Given this list of marker genes ING4, TFDP2, IRX4, KDM1A, PTGES2, DLX1, SBNO2, MIR137, EIF4A1, AHI1, MAP2K7, TCF20, NOTCH3, HAND2, E2F2, ZNF563, MIR24-1, CREB3, SREBF2, UHRF1, SMARCA2, UBE2E1, NCL, PPARA, ZBTB48, MED13, EBF4, BMAL1, DLX5, KLF4, MAPK3, ZNF780B, PTMS, NCOA6, INHBA (inhibin subunit beta A), ZNF292, MT3, HIVEP3, PID1, PAXBP1, NANOS1, TRIM24, TRA2B, EP300, ILF2, MIR365A, SIX3, POU2F1, OSR1, KLF7, CCNB1, BRD7, RBMY1A1, MEIS3P1, RXRB, PQBP1 (polyglutamine binding protein 1), SIX2 (NCBI Gene Id 10736), GABPA, SALL1, STAT4, ARGLU1, WWP2, RC3H1, TGFB2, CNOT3, CKAP2 (cytoskeleton associated protein 2), ZNF496, ONECUT1, TFR2, S1PR1, KDM7A, UBTFL6, UBP1, PRKD2 (protein kinase D2), GTPBP1, UPF1, PELP1, NR1D1, MSX1, ATM, MECOM, TOX, TBP, WWOX, ESRRG, RTRAF, GATAD2A, NR5A1, MIR18A, DLL1, CNOT2, IKBKB, TRIM52, DNM3OS, MIR26B, PLPP3, ESRRB, TLR9, TAF6L (NCBI Gene Id 55310), ICE2, ZNF550, ZFP36, NEUROD1, RBBP7, TNKS1BP1, CCAR1, ST18, IKBKG, SMAD5, CLOCK, EXOSC9, NHLH2, SHH, ARRB1, AGRN, ACTR5, TBX20, ZBED1, WDR43, LIF, FZD7 (frizzled class receptor 7), ZNF212, CAND2 (NCBI Gene Id 23066), ARID4B, FOXA3, MIR424, NEUROG3, MGA, TEAD1, PHOX2B, TNRC6A, MACC1, IL1A, PSEN1, PDLIM1 (NCBI Gene Id 9124), MEF2A, DAB2IP, MBTPS2, MITF, BSX, GIGYF2, TFAP2A, DCPS, HOXA4, EGLN1, CAMTA2, ZNF287, MIR519D, HMBOX1, RBMY1J, RBPMS (NCBI Gene Id 11030), PNLDC1, TADA1, RGCC, RREB1, TNF, ATF7 (activating transcription factor 7), TBX1, TMPRSS6, CDK5RAP2, TCF12, EGR1, BLM, PAX3, CD86 (CD86 molecule), TRIM31, CCNT2, MIR302C, BCL11A, CCNK, ZBTB18, PAX6, MIR93, LIN28B (NCBI Gene Id 389421), PIK3R1, PF4 (platelet factor 4), ATF2, YEATS4, CCN1, ZNF24, CRTC3, MET, PLAG1, GLI3, IL4I1, PSIP1, TRIM21, SPX, AR, HDGF, IER2, DIS3L2, MEIS3, ELF1, BCL2L12, WNT3A, MRTFA, APEX1, NFKB1, RIPK1, MSGN1, CHCHD2, SRF, DND1, IRF3, TAF1L, NKX2-6, TP63, HIPK2, ECD, PKN1, EGR3 (NCBI Gene Id 1960), MYRF, WASL, CPEB3 (NCBI Gene Id 22849), SMAD2, YTHDF3, ARNT2, MAVS, PRKD1, TCERG1, FOXF2, BUD23, ZNF516, IL6, PPRC1, HOXB9, SFRP2, THRAP3, OSM, ZNF407, DCN, BEX1, MIR708, EN1, MED29, TOPORS, XIST, TGFB3, HELZ2, CDC5L, FOXP3, NFE4, SMAD4, RBM15, NR4A2, ZNF711, YY1, MIR423, CHD4, MIR485, BPTF, NR4A3, FOSL2, DUX4, GATA5, NUP98, PITHD1, IRF1, MSL2 (NCBI Gene Id 55167), CCDC62, SPIB, PAXIP1, RBBP4, SMAD9, DRD2, NFE2L1, HOXC13, CLNS1A, CAMKK2 (NCBI Gene Id 121657), EPC1, BCLAF1, FIGLA, NCOA4, MIR483, MIR130A, PPP1CA, PER2, SMARCD2, NCK2, FGFR2, IL17F, GABPB1, THAP11, F2R, JUNB, XBP1, GRHL3, ZFP36L2, RGMB, FSTL3, GREM1, HAND1, FOXM1, PLAGL2, GATA6, NOL11, TADA2B, SF3B1, BTRC, CD81, SS18, FLI1, CREB3L2, BMPR1A, ELF2, NR1H4, PSMC6, SAMD4A, SOX3, CNOT8, RFXAP, MAML2, TMF1, SLC39A5, FGF1, HIVEP1, JMY, CDON, NFATC2, DEK, NANOG, NAA15, FXR2, MIR128-1, SKAP1, SOX9, LHX3, ZNF750, TAF5, BMPR1B, PCBD2, EIF2AK3, ATRX, PLSCR1 (NCBI Gene Id 5359), APBB2, TOX2, TNNI2, HAS3, IFNL1, ZNF76, DHX9 (NCBI Gene Id 3450), HOXA2, UCHL5, CSRNP3, NR5A2, CHURC1, LRP5, NOTCH4, RRN3, MEF2B, MIR125B1, ZBTB7C, ZNF593, HOXB4, EEF1D, PSMC3, MIR543, TAF2, NR2F1, MBTD1, MYOCD (myocardin), ZNF268, TFPT, DLX2, ETV6, ZXDA, MIR181B1, NFIC, SUPT4H1 (SPT4 homolog, DSIF elongation factor subunit), HSPA5, SERTAD1, MYCBP, SATB2, KLF10, CHD6, MIR27A, RBM23, ATMIN, MED18, ZEB2, NAT14, MALAT1, ZNF597, HCFC1, ZNF410, E4F1, MRTFB, RBMY1D, WNT8A, TET1, ZIC2, ATOH7, APBB1, NR1I3, ZNF423, ABHD14B, TASP1 (taspase 1), STAT5A, ACTB, ZNF776, POU4F1, MAD2L2, PDX1, ATF6, MAML3, NOCT, ARF4, SPDEF, FOXJ1, IGF2BP1, BCL9L, NPAT, RPTOR, GATAD2B, IRF2BPL, PARP9, ZNF335, BRD4, ETS1, ELK4, TRA2A, SMARCA4, PRMT5, RARA, LHX1, HNRNPAB, ATOH1, IL1B, TNFSF8 (NCBI Gene Id 944), CXCR3, NR0B2, HSF5, MIR103B1, PNPT1, EPC2, ZSCAN2, ASXL2, GSX1, PAN2, SRY, MTDH, IL13, NKX6-3, ATXN7, DHX33, AP3D1, KDM3A, FGF23, SQSTM1, CD38, WDR77, MED9, MED12, RYBP (NCBI Gene Id 23429), E2F1, MYOD1, ELF4, GLIS1, FOXI1, TP53BP1, PPP3CA, KMT2C, PPP3R1 (protein phosphatase 3 regulatory subunit B, alpha), CREB3L4, PABPN1L, COL1A1, IGF2, PSRC1, NKX2-5, MIR98, MLX, NFKB2, MYD88, PSMC3IP, CCNA2, TBX21, EPCAM, PPP3CB, TAF4B, MLLT11, SRCAP, SLC30A9, CAPRIN1, HDAC3, EFCAB7, NFYA, SMO, ARID4A, MIRLET7E, ESR1, ETV2, TAF6, MAFF, WNT7A, MED24, SUPT16H, TNIP1, APLN, MAPK14, ACTN4, EHF, KPNA6, CXCL10, FOXC2, CAND1, ANXA2, AGT, SCX, TLX1, NEAT1, LEF1, GDNF, BRD8, HES5, SOX30, MAP2K1, KAT2A, MAFB, SERTAD3, LHX2, UPF3A, QKI, SOX10 (NCBI Gene Id 8223), WDR75, NME2, TP53INP2, TEF, RBMY1E, FZD4, MLLT3, NPAS2, SMAD3, POLR2G, NR1I2, RLF (NCBI Gene Id 6018), MIR149, DXO, RIDA, RFXANK, GATA4, KHSRP, PDE12, ZNF728, MED14, MEIS1, MIR19B1, SENP1, RORB, NKX6-1, TOP2A, GATA1, CIITA, MED25 (NCBI Gene Id 81857), TRIM38, MIR544A, BNC1, SNX5, PAGR1, CNOT10, ATF1, PLA2G1B, CEBPA, DDX3X (DEAD-box helicase 3 X-linked), MMP12, MED23, THAP3, MED26, TFAP2D, ING2, RBPJL (recombination signal binding protein for immunoglobulin kappa J region like), ZFPM2, PIN1, MEPCE, SSBP3, NEUROG1, MIR495, TCF7L2, TP73, THRB, SERPINF2, LMO1, BRDT, PRMT2, HYAL2, SP1, UTP15, PPARG, DVL2, CAMTA1, ZNF513, POU4F2, ARHGEF11 (NCBI Gene Id 9826), MED19, REST, IRX6 (NCBI Gene Id 79190), UBTFL1, STH, PRR5L, TEAD4, IKZF4, OGG1, DMRT2, PRPF6, ZBTB38, HEATR1, MTA2, NCK1, RPS6KA1, ZIC3, MIR486-1, SLC38A3, ROCK1, SGF29, HHEX, AKIRIN2, KDM8 (NCBI Gene Id 79831), POU3F3, TRIP11, ZXDC, ESR2, MIR885, CTCF, RPRD1B, RBM14, DVL3, ARID1A, PMF1, NKRF, LMO4 (LIM domain only 4), IL17A (interleukin 17A), PAF1, PICALM, SMARCA5, GLI1, IL23A, MED6, LDB2, VSX2, HOXB3, TXK, RELA, FOXD2, PARN, PRDM15, NR1D2, RORC (NCBI Gene Id 6097), MID2, GRSF1, MYSM1 (NCBI Gene Id 114803), HNRNPU, MIR125A, ZBED4, NFATC4, ACVRL1, ELL2, BRD3, TBL1X, PWWP2B, TBR1, LEO1, ATN1, DDIT3 (NCBI Gene Id 92982), SCAF8, BACH1, KLF1, CDH1, LITAF, FUS, SNRNP70, TGFBR1, RBMY1F, KAT6A, TAF1, TAF10, CREBBP, MEOX1, YWHAB, PRDX6, PHOX2A, WAC, KAT7, NFATC3 (NCBI Gene Id 82543), MIR100, ZNF431, USF1, EDRF1, CDK12, LDB1, MORF4L1, ZNF329, MBD3, WNT11, MOSPD1, TBX22, TFAM, TAF4, ANKRD49, POU4F3 (NCBI Gene Id 5459), ACTN2, NPAS4, TNRC6C, MEN1, HDAC5, XPA, SOX11, PPM1A, RFX2, MIR204 (NCBI Gene Id 406987), SUPT20H, GTF2A2, CIRBP, NAMPT, PIM2, CREBL2, NRIP1, WWC1, POU2AF2, AGO2, POU3F2, SPAG8, TAF5L, NR2E3, PSMD9, MED28, CDC73, FGF4, PRDM11, DLX3, HAX1, USP21, CDK7, HOXC11, LMO3, FHOD1 (formin homology 2 domain containing 1), IRF5, SLC9A1, RGMA, RPS6KA5, SMARCB1, NFKBIB, DMAP1, PRDM2, LILRB1, MLXIPL, NAA16, ZNF281 (NCBI Gene Id 23528), NLRP3, ZIC1, MYF6, PUS1, SOX12, BCL11B, E2F3, MYRFL, RFC1, ARID5A, MED8, DHX36, MED30, TENT4B, TACC1, WWTR1, ZNF341, TOB1, PHF8, NEUROD2, NKX2-2, KAT2B, NPAS3, FOXA2, PAGE4, BARX2, ERCC6, ADIRF, SCAND1 (NCBI Gene Id 92786), CITED2, RERE, MIR29B1, RAI1 (NCBI Gene Id 6600), SFPQ, MEF2D, ITGB1BP1, EP400, MIR517C, TBX10, MIR497, CAPN3, CEBPE, CGA, BRCA2, JMJD6, MIR625, ZC3HAV1, ZNF148, TRIM16, AGO4, CCNT1, AAMDC, SHC1, PFKM, MIR655, PRPF19, DDRGK1 (NCBI Gene Id 65992), ELF5, LPIN3, KARS1, RBM24, ASCL2, FANK1, HOXD4, STING1, MIR320A, ACTR8, CARM1, TBL1XR1, TAL1, ZFY, EGR2, ID4, RELB, RUVBL2, TCF4, MSANTD1, EIF5A, MED16, MED11, MIR214, OTX2, TRIM32, SPP1, TRIM8, HDAC1, ZKSCAN3, CASK (NCBI Gene Id 8573), NFE2L2, PKM (NCBI Gene Id 8127), VDR, ID2, JPX, ABLIM1, CDCA4, SMARCE1, ALX4, SMARCD1, CDK8, FTO, ZNF639 (NCBI Gene Id 51193), P2RY1, MAP2K5, IGF1 (insulin like growth factor 1), SMARCC1, NIF3L1, FAM170A, NUP62, ABLIM3, DCAF6, PBXIP1, RBPJ, OVOL2, YAP1, MIR34B, SP3, NPM1, CREB5, HELT, ATF6B (NCBI Gene Id 87886), ADRB2, CSDE1, GFI1B, CSRP3, MIR181C, SMARCD3, TLR4, GBX2, IFI16, SERTAD2, MED17, SF3B5, SMARCAD1, EGF (NCBI Gene Id 1950), CX3CL1 (C-X3-C motif chemokine ligand 1), NGFR, TAF12, YY2, ZC3H18, SIRT2, DIMT1, JUP, TFAP2E, CALCOCO1 (NCBI Gene Id 57658), MIR337, EDN1, ZNF609, KMT2E, RUNX1, F2RL1, DCP2, HLF, ASCL3, POGZ, SPI1, SP100, MAPRE3, WAS, DTX1, TWIST1, BARHL1, PIH1D1, MED27, NANOS2, ZNF746, HMGN5, APOE, IRX3, BTG2, MIR223, FOXC1, CTR9, DDX41, NR2F2, NT5C3B, LMO2, CDX4, MBD2, ITGA8, ATXN7L3, CEBPZ, ZBTB16, ZNF507 (zinc finger protein 507), DDX11, STAT3, ERBB2, TBX6, MIR665, NDN, NRF1, CD4, OSR2, KLF13, HES1, MDK, PRRX1, MED10, HGF, GDF7, GABPB2, MAFA, TP53INP1, TNFRSF1B, NKX2-1, TRMT112, MAZ, MTA3, PPARGC1B, FOXE1, RARG, MIR212, ABL1, NOD2, ARID3A, IRF9, MED13L, SOX8, KDM5A, SSBP4, CEBPB, HEYL, NEUROD4, TNFSF11, MIR142, TNIP2, ALX1, HOXD3, MLH1, TNKS, TGFB1I1, KLF5, INO80, YTHDF2, PRL, MIR9-1, CNOT11, NIBAN2, PKNOX1, MAPKAPK5, HMGB2, GRHL1, HTATIP2, BCL3, PAX9, NKX3-1, TCF15, MIR517A, ELL, KLF12, CREM, DIS3, STRN3, HMGN1, NR2C2, MCIDAS, FEV, CDK2, BRPF1, CELF1, CAVIN4, PIWIL2, NANOS3, POU2F2 (NCBI Gene Id 5452), DEAF1, IRF2, TFCP2L1, BRCA1, PEG3, FOSL1, PPP1R10, E2F8, DTX3L, HRAS, BLOC1S2, PRKCB, SIX5, MYC, PATL1, MEAF6, NFKBIZ, SMAD6, NELFE, NFYB, SETX (NCBI Gene Id 85506), ZNF318, PLCB1, ILF3, CEBPG, NPNT, PBX2, PTOV1, PTMA, WDR5, ZBTB7B, ETV4, TDRD3, ZFP64, TNFRSF1A, MKRN2 (NCBI Gene Id 29073), PTH, FGF10, RFX6, GLI2, UBTF, DMRT1, PARP1 (poly(ADP-ribose) polymerase 1), VEZF1, CENPJ, STAT1 (NCBI Gene Id 6772), GPBP1, FBXW11, MYCN, NFATC1, HLTF, PURB, ANKRD1 (ankyrin repeat domain 1), INO80C, CNOT7, MIR133A1, ZFAT, DOT1L, CEP290, EYA1, ZNF345, PYGO1, MRPL12, GCM1, NOTCH2, BMAL2, MDFIC, NLRC5, RNF4, CASZ1, PDGFB, PER1 (NCBI Gene Id 5187), ELAVL1, BORCS8-MEF2B, CDK13, PKD2, MIR140, FOXK1, IFT74, SFR1, PATZ1, ACTR6, CNOT6L, PATL2, EDF1, CREB1, SOX21, KLF15, MIR203A, KMT2B, HNF1B, USF2, PWWP2A, BCAS3, JAK2, EGFR, AGO3, XRCC6, TLR2, CHCHD10, FOXO4, PRDM16, MIR564, BAMBI, CTBP1, HOXD9, GPS2, MICAL2, PINK1, FUBP3, FOXO1, CREBZF (NCBI Gene Id 58487), FOXN1, BTBD18, CHEK2, EAF2, ABT1, SOX2, MIR106B (microRNA 106b), PUM1, RBM3, ZNF541, PLEKHN1, ACTR3, HOXA9, NFYC, PITX3, CEBPD, EVX1, E2F5, TLR7, ZNF395, BUD31, RFX4, SUPT5H, PTF1A, IKZF3, MIR206, MYBL2, SMARCC2, NR1H2, SFRP1, GTF2A1L (NCBI Gene Id 11036), PROX1, FGF7, FOXA1 (forkhead box A1), MAMSTR, ETS2, FADD (NCBI Gene Id 8772), MLXIP, MIR185, ETV5, MIR211, CDK5RAP3, CAPRIN2, LBH, PROP1, MED21, RARB, NOS1, MLIP, ARID5B, CHUK, GSK3A, TBX5, KMT2D (lysine methyltransferase 2D), DDN, MYBBP1A, TAF8, SMYD3, WNT1, HCLS1, ZGLP1, CD274, RFX5, MYF5 (NCBI Gene Id 4617), MSTN (myostatin), MARS1, TFAP2C, ZP3, GALR1, PTEN, MYOG, MED12L, GMEB1, KANSL1, GCM2, POU5F1, SETD3, HNF4A, CHD7, MIR302A, ERG, SRA1, RHOQ, AFAP1L2 (NCBI Gene Id 84632), ZFP36L1, BMPR2, ABRA (NCBI Gene Id 137735), TBX15, JAG1 (jagged canonical Notch ligand 1), NMD3, NR2E1, RRP1B (ribosomal RNA processing 1B), MIR520C, NUFIP1, PRKDC, JADE1, MED1, HCFC2, ICE1, MIR373, ATXN1, ZFHX3, HNRNPD, NACA, H2AZ1, PAX7, MMS19, HMGB1, NFAT5, LYL1 (LYL1 basic helix-loop-helix family member), HNF4G, SNAI1, NFKBIA, SUB1, MAML1, FEZF1, TRIM22, RET, CTBP2, AHR, GRIN1, XPC, SIX1, NR6A1, CNOT1, BHLHA15, PITX2, ZSWIM8, PIK3R2, ZNHIT1, CNBP, RSF1, EBF2, KLF6, MIR326, CYTL1, EXOSC10, GNL3, HMGA1, AGTR2 (NCBI Gene Id 186), BMP3, EGR4, ZFP90, TAF7, KDM6B, MIR608, PAN3, MOV10, MAPK7, LUM, LMX1A, NIPBL, CRTC2, CNOT6, CDH13, MIR20B, INO80B, FOXD3, COQ7, SUPT7L, CD80, VEGFA, RBCK1, HLA-DRB1, HNRNPK, TFEB, PYHIN1, PPARD, TFE3, MIR340, MEX3D, RBMXL1 (NCBI Gene Id 494115), TRERF1, SSBP2, PTBP1, CHP2, PLAC8, PKD1, GAL, FEZF2, FOXF1, GATA3, HOXA7, SETD4, GPER1, OLIG1 (oligodendrocyte transcription factor 1), ZNF71, PTPRN, ZMYND8, WDR82, TAF13, LRP6, CXXC1, HDAC2, RNF6, SOX14 (NCBI Gene Id 8403), PIM1, PHF20 (PHD finger protein 20), TUT7, HEXB, FOXN4, AKAP8L, MESP1, IL33, PARK7, MYB (NCBI Gene Id 4602), ASH1L, ACTR2, MED20, FOXJ2, ZNF784, TRIM14, SYNCRIP, LHX5, SUPT3H, MEOX2, BARHL2, ZEB1, PUM2, IPPK (inositol-pentakisphosphate 2-kinase), TERT, NR3C1, CAMK4, HOXD13, ATF7IP, POU2AF1, RNF20, RFX7, LARP7, TOX3, ELK3, TADA2A, CITED4, TRAF6, DAB2, TBX2, SUPV3L1, BAZ1B, MED22, IRF6, ATOH8, TBXT, INPP5K, MTF1, TRIM5, SKI, HOXB5, ATF5, MIR200C, NHLH1, BMP7, ZNF300, EPO, TFDP1, IFNB1, SOST (sclerostin), KANSL2, KLF2, FOXK2, DBP, NFIA (NCBI Gene Id 4774), MED7, IHH, MAP3K12, TRIM13, NUPR1, PIWIL1, ZNF485, DDX21, MED15, DCP1A, BCL9, AP3B1, UBE2V1, PRDM5, MIR501, WNT10B, TSC22D1, YTHDF1, CSF3, YAF2, ITGA6, SF3B3, METTL14, ASXL1, PPARGC1A, RIPK3, ARHGEF2, BMP4, MYBL1, BMP6 (NCBI Gene Id 7964), SLC11A1, VGLL1, TARDBP, LPIN1, RIGI, MIR4286, RNF14 (ring finger protein 14), MYO1C, THRA, NDP, FSHB, DNAJC2, BMP5, TBK1, TBX3, NFE2, WNT5A, MRGBP, MIR663A, FOXH1, BHLHE22, MEF2C, CDKN2A, PWP1, GDF6, TRIM44, SNW1, IL5, KDM4C, JUND (NCBI Gene Id 3727), FOSB, OTX1, TLR3, EBF3, TRIM71, HJV, MECP2, NSD3, MAP3K5, FHL5, MIR181D, CDK9, NUCKS1, TRIM28, CRLF3, ZNF462, METTL23, PAX2, IL31RA, RNASEL, TADA3, MIR9-1HG, ASXL3, HDAC4, GTF2A1 (general transcription factor IIA subunit 1), ING3, TOX4, RAX2, MAPK15, CTNNB1, ZNF263, CD28, TRIP4, INO80E, RAF1, SIX4, NRL, RASL11A, TP53, FOS, FGF2 (fibroblast growth factor 2), ACVR1, ZNF219, CREB3L1 (cAMP responsive element binding protein 3 like 1), HOXB1, KLF14, FOXJ3, LSM1, MIR151A, PHB1, TFAP2B, EAPP (E2F associated phosphoprotein), IL2, NEUROG2, HOXD10, DCP1B, ACTL6B, MAGED1, EOMES, RPS6KA3, ZNF580, BHLHE23, ERCC1, ZNF827 (zinc finger protein 827), DDX17 (DEAD-box helicase 17), GRHL2, BMP10, SP7, HSF1, TOP2B, ATAD2, ING1, MEIS2, MLLT6, MAP2K3, PBX4, RUNX3, KAT5, UTF1, ASPH, STK16, MTOR, PPP1R12A, TAF15, TUT4, HOXA1, RUVBL1, GALR2 (galanin receptor 2), KANSL3, TAF11, TBX19, CELA1, CD200, NFIL3, AKT1, E2F4, LMX1B, TRRAP, ERBB4, MUC1, LMO7, GLIS3, TCEA1, SLC40A1, IER5, RHOG, MIR193A, CELF3, VPS72, FZD1, PBX3, SPIN1, YBX1, NCBP2, FZD2, GPBP1L1, NCOA3, SMAD1, NFIB, IL26, TGFB1, WNK1, RPS6KA4, TET3, RIOK1, ZNF175, CRX, ADCYAP1, ETV1, WBP2, MZF1, SETSIP, ISL1, GLMP, TFEC, CDKN1C, NFRKB, HOTTIP, TEAD3, CHD8, E2F7, LBHD1, ROCK2, ZNF304, HINFP, ESRRA, ACVR2A, TAF9, FZD5, STAT6, MIR210, PCGF5, UBE2L3, PBX1, PRKN, ZBTB49, ISL2, TENT4A, NCOA7, MAX, MAP2K2, SENP2, MIR191, PGR, MIR106A, MYT1L, RUNX2, NR1H3, NOTCH1, ZNF131, TFCP2, BCL10, ENY2, DAXX, DAZAP1, CREB3L3, USF3, MYDGF, STAT2, ARID3C, BMP2 (bone morphogenetic protein 2), SALL2, MIRLET7B, ATF4, TRIAP1, IL18, MIR130B, WNT2, ASCL1, MIR200B, KMT2A, XCL1, EIF4ENIF1, MIXL1 (Mix paired-like homeobox), NEK4, MAFG, PAX8, PITX1 (paired like homeodomain 1), HOXA11, FIZ1, HOXA10, FBLN5, PRDM10, UPF3B, NKX2-3, MIR199B, ARID1B, TCF3, FOXO3, ONECUT2, TEFM, MED4, UCN, SOX15, TRIM15, VGLL2, CREBRF, HMGA2, IL11, IL25, LHX4, MC1R, TRIM37, AIP, SIRT1 (sirtuin 1), CCPG1, HOXA13, KAT6B, HIF1A, CASC11, DYRK1A, MAF, CNOT4, CD40, NSD1, GATA2, TTC5, CITED1, RAX (retina and anterior neural fold homeobox), TRIM27, ZC3H8 (NCBI Gene Id 84524), SOX18 (NCBI Gene Id 54345), MSL3, DYRK1B, FOXL2, MIR181A2, TRIM25, EN2, AKIRIN1, PHF2 (NCBI Gene Id 79448), ALKBH5, WBP2NL, ZFPM1, GTF2F2, MED31, IFNG, RORA, WNT4, MTA1, GPATCH3, CSRNP1 (cysteine and serine rich nuclear protein 1), FXR1, PHIP, TLX2, ARL2BP, HEY1, HEY2, RBMY1B (NCBI Gene Id 378948, RNA binding motif protein Y-linked family 1 member B), VENTX, HSF2, KAT8, PABPC1, SIRT7, POU2F3, ZC3H12A, SAMD4B, SHOX, NUP85, RIOK2 (RIO kinase 2), PSMC5, CCNC, CARF, STAT5B, BICRAL, DNM2, RFX3, VHL, PCK1, PTCH1, ACSS2, METTL16, PKP1, JUN, NELFA, RB1, IRF7, AGO1, ZFX, QRICH1 (glutamine rich 1), ZNF616, MIR192, HMX2, ELL3, ZC3H12D, YWHAH, SS18L1, TRIM62, TAF3, ANKRD23, MIR135B, ZSCAN21, CNOT9, MIR96, MIR190B, MIR329-1, MCRS1, AIRE, RAP2C, HOXC10, IRF8, SOX7, MLLT10, MIRLET7A1, PIAS1, AKNA, MORF4L2, SMARCA1, MIR146A, PRKAA1, OLIG3 (NCBI Gene Id 167826), RXRA, OLIG2, TBX4, CDX2, GTF2I, RXRG, POU2AF3, ENG, NCOA1, MIR562, TCF21, PLAGL1 (PLAG1 like zinc finger 1), USP22, NODAL, RIPK2, SPIC, MIR519A1, MIR1-1 (NCBI Gene Id 406904), CTCFL, POMC, SREBF1, HOXA5, ZMIZ2 (NCBI Gene Id 83637), TEAD2, UBE3A, PCBP1, HOXC4, MIR20A, GTF2F1, MIR27B (microRNA 27b), BICRA, NEUROD6, APP (NCBI Gene Id 351), ACTN1, AUTS2, METTL3, INSR, NFIX, SALL4, SOX4, TBX18, DVL1, S100A10, IL4, CELF4, NCOA2, RBMX, NFATC2IP, TFAP4, WNT6, BCLAF3, BIRC2, NCBP1, ELK1, ILK, TESC, MAK, ELF3, MIR23A, PHF5A, GTSF1, CDX1, RNF10, CSRNP2, ACTL6A, POU1F1, MIR342, CHD3 (chromodomain helicase DNA binding protein 3), EPAS1, GLIS2, MIR30B, USP16, ONECUT3, NOG, EZH1, MLLT1, MIR491 (microRNA 491), TET2, SOX1, TNRC6B, CCDC124, LYAR, CBFB, RIT2, ARID3B, RC3H2, GDF2, HNF1A, ARX, RNF187, NKX2-8, FOXD1, LPIN2, PRDM4, CAMK1, NR4A1, MSL1, POU3F1, CD74, FOXR1, GTF2H1, BATF, SOX17, ATF3, RNF40, SUMO2, YES1, PPP2R5B, MIR195, WT1, ZBTB17, HES6, INO80D, KCNH2, ARMCX3, PML, SETD7, REL, HOXB7, MIR145, ZNF143, IL10, SEC14L2, HOXB2, MIR19A, ZBED3, HOXD8 (homeobox D8), ZMIZ1, OGT, ARNT, COPS5, MIRLET7C, IRF4, PCBD1, PAX5, PAIP1, GALR3, CRTC1, ZNF398, here is a description of the gene set: studied in species Homo sapiens Human Gene Set: GOBP_POSITIVE_REGULATION_OF_RNA_METABOLIC_PROCESS Any process that activates or increases the frequency, rate or extent of the chemical reactions and pathways involving RNA.